Given this list of marker genes TAF12, NUDT1, FAM72A, CDK1, FLNB, TMED10, VIM, ADAP1, MYL4, MFSD2A, TUBGCP2, MRPL42, RFC5, COPS3, SHMT1, TSEN2, BUB3, LSM12, CD9, PPA1, SYCE2, HMGN2, FBL, ADK, PSMB2, TNFSF10, UBE2L3, RPA3, CEP72, COPS4, GSTO1, CRELD2, SULT2B1, HIRIP3, PSMD6, TUBA4A, PSMC4, MCM10, EEF1D, PSMC3IP, AURKB, PPIL1, SERPINE2, MCM7, SNRPA1, GEMIN6, PRIM1, URB2, RANBP1, AFG3L1P, NF1, TIMM17A, POLR2L, RRM2, CARS1, CAPG, LSM3 (LSM3 homolog, U6 small nuclear RNA and mRNA degradation associated), PGK1, UXS1, CENPS, MECR, AGPAT5, HAUS7, POLD1, BANF1, ASF1B, USP49, UCHL3, ERH, RAD51, GMNN, RFC3, SFXN1, AURKA, SLC30A4, LSM2, TMEM106A, TNFRSF9, PMM1, ZMYND19, SNRPD1, CDKN3, PNO1, MYC, CS, RIPK3, HEATR3, IFI30, CLYBL, MDC1, NUP37, CFAP20, MRPL18, CKS1B, MIX23, BATF, FAM136A, FKBP2, KYAT3, DSCC1 (DNA replication and sister chromatid cohesion 1), DUT, POLQ, LYAR, CNIH4, SHMT2, NOP56, CLTB, CDCA3, LSM7, BEX3, LDHA, UCK2, AHSA1 (NCBI Gene Id 10598), CDKN1A, IL1R2, RNPS1, MRTO4, POLB, UBE2S (ubiquitin conjugating enzyme E2 S), MORF4L2, NAMPT, RAD18, MAFF, FADS1, CCRL2, GEMIN5, HAUS1, PPIE, CAD, POLL, EME1, TPI1, IMPA2, GGT1, PRMT7, UMPS, CISD1, PRIM2, CENPN, TRMT5, CALM3, NANS, LAP3, ARHGAP21, ANXA2, SPC24, BCKDK, SAAL1, POLE2, NUP43, BIRC5, JPT2, SGO1, PRDX1, IARS1, GINS1, CDK4, ZDHHC3, PANX1, IRF4, MRPS22, CHML, PRKAG1, CENPP, HSD17B12, ORC6, CYP20A1, PBK, PARK7, SMYD2, POLD2, COQ7, ISOC1, ROM1, CCNB2, CSTF2, NHP2, SEC13, ZIK1, RBBP7 (NCBI Gene Id 5931), CDK2AP1, TK1, MIS18BP1, TEX15, FBXO5, here is a description of the gene set: Genes up-regulated in T reg: induced versus failed induced. from publication Haribhai D, Lin W, Edwards B, Ziegelbauer J, Salzman NH, Carlson MR, Li SH, Simpson PM, Chatila TA, Williams CB (PMID 19265124) Human Gene Set: GSE14415_INDUCED_TREG_VS_FAILED_INDUCED_TREG_UP species: Homo sapiens The gene expression profile of peripheral Foxp3+ natural regulatory T cells isolated from Foxp3/EGFP bicistronic mice was compared to that of in vitro-induced regulatory T cells and to CD4+ conventional (Foxp3-) T cells. The role of the regulatory T cell transcription factor Foxp3 in shaping the transcriptosomes of natural and induced regulatory T cells was analyzed using mice expressing a mutant FOXP3-EGFP fusion protein (Foxp3deltaEGFP). We used gene expression microarrays to examine the transcriptional programs of natural and induced regulatory T cells and the function of Foxp3 in organizing the transcriptosomes of the respective cell type